The following is a description of a gene set: The chemical reactions and pathways involving flavones, a class of pigmented plant compounds based on 2-phenyl-4H-1-benzopyran-4-one (2-phenylchromone). species: Homo sapiens Human Gene Set: GOBP_FLAVONE_METABOLIC_PROCESS, and this is the list of marker genes: UGT1A9, UGT1A10, UGT1A8, LCT, UGT1A1, UGT1A7